The following is a description of a gene set: species: Mus musculus Any process in which a new genotype is formed by reassortment of genes resulting in gene combinations different from those that were present in the parents. In eukaryotes genetic recombination can occur by chromosome assortment, intrachromosomal recombination, or nonreciprocal interchromosomal recombination. Interchromosomal recombination occurs by crossing over. In bacteria it may occur by genetic transformation, conjugation, transduction, or F-duction. Mouse Gene Set: GOBP_DNA_RECOMBINATION, and this is the list of marker genes: Rad21l, Cd28, Ccnb1ip1, Poln, Nsmce1, BC037156, Polm (NCBI Gene Id 54125), Swsap1, H1f5, Ercc1, Wdr48, Mre11a (MRE11A homolog A, double strand break repair nuclease), Rpa3, Trrap, Mrnip, Usp51, Exosc6, Rif1, Eme1, Zmynd8, Exosc3, Smc5, Ccr6, Kdm1a, Ino80d, Crebbp, Rad21, Rtel1, Dmap1, Iho1, Tfrc, Dclre1c, Foxp3, Nfrkb, Rec114, Pgbd5, Kin, Swap70, Prmt1, Cntd1, Morc2b, Hdgfl2, Slx1b, Kmt5b, Exo1, Ino80c, Fan1, Ppp4r2, Cd40, Meiob, Zfp365, Kmt5c, Polq, Timeless, Recql, Tert, Ung, Xrn2, Top3a, Setx, Terb1, H1f1, Pot1b, Samhd1, Eid3, Abl1, Mcm5, Nipbl, Senp3, Zscan4c, Rad51b, Slc15a4, Plk1, Rmi1, Aplf, Yeats4, Terf2, Cgas, Ints3, Cep63, Brd8, Shld3, Peli1, Ube2b, Msh5, Hfm1, Pcyt1a, Hspd1 (NCBI Gene Id 15510), Aicda, Tep1, Tnfsf4, Sycp1, Psmd14, Il2, Rpa2, Supt6, Il27ra, Was, Mei4, H2ax, Nucks1, Zgrf1, Actr8, Palb2, Msh3, Mms22l, Ruvbl2, Ino80b, Tcf3, Tfpt, Bcl11b, Stat6 (NCBI Gene Id 216450), Rag2, Rnf138, Icosl, Kash5, Rec8, Chd4, Hrob, Foxp1, Pif1, Actl6a, Shld1, Clcf1, Msh4, Cyren, Majin, Cdc45, Tex19.1, Tgfb1, Nsd2, Mcm2, Zranb3, Xrcc1, Rfwd3, Spo11, 4930447C04Rik, Nfkbiz, Rag1, Brca1, Pms2, Kmt5a, Rnf138rt1, Topbp1, Tnfsf13, Epc1, Lef1, Yy1, Brip1, Mcmdc2, Top6bl, Wrap53, Pogz, Uchl5, Nbn (nibrin), Parp1, Gins4, Smchd1 (SMC hinge domain containing 1), Rad51d, Actb, Fancb, Radx, Il4, Pias4, Atm, Fus, Nabp2, Actr5, Csnk2a1, H1f0, Lig3, Mus81, Nhej1, Rhno1, Ndfip1, Actr2, Polb (NCBI Gene Id 320892), Cenps, Rad18, Cd40lg, Rad52, Lig4, Slx4, Rpa1, Fancd2, Mcm4, Ankrd31, Xrcc5, Mcm3, Hus1, Parpbp (NCBI Gene Id 75317), Ezh2, Msh6, Helq, Chek1, Cdc7, H1f4, Rad51, Morf4l1, Dcaf1, Sem1, Zfyve26, Klhl15, Xrcc6, Lig1, Rev3l (REV3 like, DNA directed polymerase zeta catalytic subunit, NCBI Gene Id 19714), Mcm9, Cenpx, Zcwpw1, Mcrs1, Batf, Rnf126, Fancm, Vps72, Htatsf1, Aunip, H1f6, Tonsl, Trip13, Sanbr, Terb2, Rad54b, Hsf2bp, Top3b, 1700028K03Rik, Wrn, Ooep, Morf4l2, C1qbp, Terf2ip, H1f2, Rnf212b, Ep400, Bard1, Mcm8, Trp53bp1, Atad5, Smarcad1, Top2b, Ercc6, Khdc3, Prkdc, Setd2, Rmi2, Mrgbp, Brca2, Ptprc, Tex15, Sfr1, Xrcc2, Recql4, Dmc1, Ubqln4, Ap5z1, Top2a, Chtf18, Ube2n, Nsmce2, Mir181b-2, Sycp3, Nono, Paxip1, Rnf168, Tbx21, Ino80, Nsmce3, H1f10, Mad2l2, Mbtd1, Pagr1a, Gins2, Kdm4d, Apex2, Mcm6, Sirt6, Brme1, Rnf212, Mir181b-1, Ercc5, Rad50, Mlh1, Inip, Shld2, Tcf7, Psmc3ip, Ifng, Gen1, Nabp1, Hmgb2, Poll, Ubr2, Rnf169, Ankle1, Mnd1, Arid2, Xrcc3, Hus1b, Mcm7, Rad51ap1, H1f8, Supv3l1, Tex11, H1f3, Rad51c, Bcl6, Shoc1, Kat5, Syce3, Ercc2, Spidr, Aste1, Swi5, Hdac10, Rpain, Blm, Sfpq, Ing3, Rnf8, Eme2, Smc6, Rad54l, Ercc4, H1f9, Zswim7, Epc2, Xrcc4, Helb, Fignl1, Fbh1, Rbbp8, Ap5s1, Ruvbl1, Meaf6, Msh2, Apex1, Hmces, Exd2, Parp3, Skp2, Recql5 (RecQ protein-like 5), Hmgb1, Prdm9, Ppp4c